The following is a description of a gene set: Human Gene Set: GOBP_NATURAL_KILLER_CELL_CHEMOTAXIS studied in species Homo sapiens The directed movement of a natural killer cell guided by a specific chemical concentration gradient. Movement may be towards a higher concentration (positive chemotaxis) or towards a lower concentration (negative chemotaxis)., and this is the list of marker genes: KLRK1, CCL2, XCL1, CCL3, CCL5, PIK3CG, PIK3CD, CCL4, KLRC4-KLRK1, CCL7